The following is a description of a gene set: Human Gene Set: HP_ABNORMAL_MOTOR_NERVE_CONDUCTION_VELOCITY studied in species Homo sapiens Abnormal motor nerve conduction velocity, and this is the list of marker genes: SORD (NCBI Gene Id 6652), GJB1, NEFL, TRIM2, SH3TC2, RAB7A, SBF2, SIGMAR1 (sigma non-opioid intracellular receptor 1), PMP22, KIF1B, MFN2, NOTCH2NLC, MED25, AARS1, MEGF10 (NCBI Gene Id 84466), LRSAM1, DEGS1, YARS1, FBXO38, CCT5, SLC5A7, ATXN1, HYCC1, GJC2, CNTNAP1, ATP11A (ATPase phospholipid transporting 11A), FXN, NALCN, BSCL2, SETX, UQCRC1, POLG, SPTLC1, LITAF, RRM2B, JPH1, SCP2, CTDP1, TDP1, GDAP1, TYMP, HPDL, PNKP, MORC2, EGR2, REEP1, MTMR2, FIG4, NDRG1, VCP, DCAF8, FGD4, LMNA, PRPS1, DNAJC3, HK1, SACS, PTRH2, LIG3, GARS1 (glycyl-tRNA synthetase 1), HSPB1, MPZ, PLEKHG5, SLC12A6, SPTLC2, TBC1D20, ITPR3, PRX